The following is a description of a gene set: species: Homo sapiens Human Gene Set: GOBP_ACTIVATED_T_CELL_PROLIFERATION The expansion of a T cell population following activation by an antigenic stimulus., and this is the list of marker genes: PDCD1LG2, TNFSF9, HMGB1, STAT5B, ABL1, CADM1 (cell adhesion molecule 1), TMIGD2, IL23A, MIR30B, STAT5A, CD24, IGF2 (NCBI Gene Id 492304), MIR21, PYCARD, LAPTM5, BTN2A2, GPAM, MIR181C, FADD, IGFBP2, CLC (Charcot-Leyden crystal galectin), IL23R, AGER, SLAMF1, BTN3A1, ARG1, IL12RB1, IGF1, CASP3, RIPK3, EPO, CRTAM, ICOSLG, FOXP3, IDO1, HHLA2, SCRIB, LRRC32, IL2RA, LILRB4, RC3H1, RPS3, IL2, PRKAR1A, PRNP, IL18 (NCBI Gene Id 3606), PPP3CA, CD274, IL12B, LGALS9, FYN